Given this list of marker genes HLA-DQB1, BRAF, HGD, LSM11, PEX3, GDF5, COL2A1, MT-ND4, RTEL1, CA2, RBBP8, MT-ND5, PDGFB, PEX10, FXYD2, NSMCE3 (NCBI Gene Id 56160), MYORG, RELN, GGCX, VPS33A, AGXT, ISG15, SMARCB1, TSC2, ANKH, ABCG8, PEX16, GNA11, PDGFRB, GALNT3, ERCC1, CYP2U1, RNASEH2A, FBN1, MYMK, PTH, CPT2, RTL1, PEX11B, MEN1, B2M (beta-2-microglobulin), OPA1, RNASET2, USP18, P4HB, ATOH7, MT-CO1, DENND5A, FGF23, CDC73, PAH, PEX19, APOB, SLC34A2, MT-TH, SLC46A1, TINF2, USB1, RIGI, ERCC6, CTC1, CTNS, CPA1, MEG3, PSMB8, HYAL1, PEX7, TRPV6, RNASEH2B, GJA1, PEX14, LRP5, ACVR1, PDCD10, CMPK2, POT1, PSMB9, AP1S2, FAM111A (FAM111 trypsin like peptidase A), CASR, ZMPSTE24, STX16, PTH1R (parathyroid hormone 1 receptor), TNFRSF1A, LDLRAP1, MGP, PCSK9, COL1A1, PRSS1, CTNNB1, SLC20A2, WWOX, KATNB1, KRAS (NCBI Gene Id 3845), ABCC6, NPM1, GNPAT, DKC1, MT-ND6, LYN, TYROBP, GATA3, ZSWIM6, COL1A2, PEX13, HLA-DQA1, RB1, PEX6, STAT1, IRF8, NOTCH3, MT-TW, ERCC8, TCIRG1 (NCBI Gene Id 8845), DNM1L, ENPP1, SUCLA2, PEX1, THRB, TREM2, SLC4A4, GNAS, SC5D, LIPA, DAG1, CCM2, PTCH2, PEX12, PEX26, NAA60, SLC12A1, PTCH1, AIRE, XPR1, IFNG (interferon gamma), FAM20C, MT-TQ, EXOSC2, NSDHL, SAMHD1, APP, SMAD6, SAMD9, NKX2-5, STAT2, TREX1, PEX5, OCLN, MT-CO2, MEFV, CSF1R, MT-ND1, NDP, SPINK1, HSD17B4, TERT, WRN, SLC26A2, FGFR1, TNFRSF11A, TNFRSF11B, CFTR, FZD4, PDE4D, PPFIBP1, WRAP53, MT-TF, AP2S1, COL11A1 (collagen type XI alpha 1 chain), AMER1, ZBTB20, SUFU, PRKAR1A, COLGALT1, GBA1, NOP10, PRSS2, KRIT1, CLCNKB, FLNB, NOTCH1, CTRC, TTC7A, SLC25A46, PI4KA (phosphatidylinositol 4-kinase alpha), KL, RNASEH2C, SNORD118, MT-CO3, SLC12A3, ERCC3 (NCBI Gene Id 2071), ACD, DLK1, DHCR7, HRAS, JAM2, LMNA, KCNJ1, IFIH1, SLC2A1, PSMG2, PSMC3, ESAM, TERC, SLC19A1, ZNFX1, COL9A1, NEU1, MT-TL1, ERCC5, ARSL, ECM1, ERCC4, FARSB, SLC29A3, LEMD3, KARS1, QDPR, ATP7B, MYO5A, PEX2, GATA5, PIK3CA, ABCG5, EBP, CYP11A1, VPS35L, GCM2, TYMS, CTSC, ADAR, DDR2, NDE1, GNAQ, PARN, ATP7A, ALPL, BMPR1B, NT5E, MT-TS2, ODC1, NHP2, MTX2, AGPS, LBR, GUSB, CCN6, LDLR, NRAS, ERCC2, ACP5, TSC1, MYMX, SNRPB, RNU7-1, here is a description of the gene set: Deposition of calcium salts in a tissue or location in which calcification does not normally occur. Ectopic calcification species: Homo sapiens Human Gene Set: HP_ECTOPIC_CALCIFICATION